The following is a description of a gene set: from publication Yevshin I, Sharipov R, Kolmykov S, Kondrakhin Y, Kolpakov F (PMID 30445619) Genes containing one or more binding sites for (ZNF274) in their promoter regions (TSS -1000,+100 bp) as identified by GTRD version 20.06 ChIP-seq harmonization. species: Homo sapiens Human Gene Set: ZNF274_TARGET_GENES, and this is the list of marker genes: ANGEL1, IMMP2L, WSB1, RASAL2, EIF2D, EFHB, AOX3P, YWHABP2, NAMPT, RPL31P63, HTATIP2, MIPOL1, ATRAID, CAPS2, TRAF3IP3, HEXA-AS1, ZCCHC2, NCOA4 (nuclear receptor coactivator 4), RPL22, UBTFL9, TP63, DPM1, SLC38A4, SRSF5, BDH1, SIDT2, TTLL5, IQCG, RPL21P7, LRRC8C, AGBL5-AS1, LINC01983, SNRPCP3, C14orf28, MT-TP, ENSG00000201701, RDH14, SNORD116-9, ACTBP12, AKAP7, SIGLECL1 (NCBI Gene Id 284369, SIGLEC family like 1), CD1E, COL4A1 (NCBI Gene Id 1282), LRRC27, PI4KA, ENSG00000234464, CLRN1, LMO7 (LIM domain 7), TPD52, LTV1, ASB13, PSMC6, IWS1, SRP54, ZNF182, PACS1, SAA2-SAA4, NAPSB, RRAGC, PSMA3, BIVM, EPB41, NXN, GTF3C2-AS2, MAPK1, HMGXB3, GCSHP2, BZW2, LINC02218, E2F3, IL17A, VPS41, MIR4273, TMEM167B, ENSG00000251922, TAT, FAM76B (family with sequence similarity 76 member B), PDE4B, BBS4, PHIP, LINC02890, TMEM19, LINC00317, LINC02278, GPR139, PHYKPL, ANXA2R, ZSCAN2, ZNF704, UTS2B, RTF1, MT-ND4, SLC39A13, POLR1HASP, ZNF791, WASH3P, ENPP5, CAPN2, AARD (alanine and arginine rich domain containing protein), SUMF1, SLC44A2, RTN1 (NCBI Gene Id 8108), RGS17P1, PSMD13, RNU6-369P, RAB3GAP2, GRWD1, ZNF324, GLI1 (NCBI Gene Id 2735), H1-4, CHTF8, PCDHA14, DST, MRM2 (NCBI Gene Id 29960), LY96, MIGA1, DBNL, RN7SL728P, ABHD12B (abhydrolase domain containing 12B), SPACA5, PSMB5, STK3, ZFHX3-AS1 (NCBI Gene Id 107984814), MEFV, PECAM1, ZFP69, HVCN1, RPS12P7 (NCBI Gene Id 100271055), ZC3H7A, MALT1, PRPS2, SRSF10, TCF7L2, STIM1, BBOX1, LCN2, PIGBOS1, FER1L6-AS2, LINC03000, SIRT1, NEIL1, MFAP3, GCNT1P3, MLIP, ATF7IP, SLC4A1APP2 (NCBI Gene Id 100422527), KIF2A, LCNL1, SNRPG, WDR53P1, EPB41L4A, INO80B, FPGS (folylpolyglutamate synthase), EFL1, MIR4473, DPH5, NAIF1, SLC1A3, UBE2D3P2, LNCRNA-IUR, CCDC71L, RNU7-110P, KRT4, HNF1A, IGLV3-29, SMPD4P1, NDUFAF4, DNM2, LINC01719, MYO1C, FIBCD1, CCDC18, GPNMB, ZNF397, NAMPT-AS1, CDC26, CROCCP2, FRMD5, MT-TS2, LIPC, IL24, HECTD1, IRAK4, FANCG, NFKBIZ, RNU6-1084P, ATXN2, IGLV1-36, RGL3, RPL17, IQGAP3 (IQ motif containing GTPase activating protein 3), RNU6-1261P, KCTD3, TYW3, SIRT3, MRPL17, GNA13, SAA2, TERB2, OSMR-DT, SIPA1L1, GGNBP1, KDM4C, TAF11L14, LUZP1, DDB2, ENTPD2, NDUFA12, DSG2, DAPK1, VENTXP4, SLC7A6, NDUFS3, ZFAND6, SPANXB1, LYSETP1, RNA5SP333, OR7A5 (olfactory receptor family 7 subfamily A member 5), LAMC3, SYNM-AS2, ERCC4, INTU, RTEL1-TNFRSF6B, EFCAB6, MITD1, YAP1, PTGER4, ITM2B, TESMIN, ENSG00000267079 (NCBI Gene Id 101927511), MTMR2, MUC6, LINC02631, UIMC1, AFDN, GFPT1, ART4, H2BC4 (H2B clustered histone 4), TRIO, LRRC36, MEIS3, DTNA, MAN1B1, TMTC1, MTND5P11, LRRC8C-DT, SKIL, ANKRD54, ZFX, ACBD6, MICU1, ZNF461, GEMIN8, CYP4A22-AS1, NOS2P1, H2AC6, DIAPH3-AS1, ANKRD22, MDM2, PANK1, ANKRD11, TANC2, ADAM10 (ADAM metallopeptidase domain 10), GCM1, ANLN, UBLCP1, PTGES2, MTND6P4, BMERB1, ENSG00000251574, ENSG00000254237, ENSG00000207751, PRC1, SREK1IP1, ATPAF2, SNORD116-7, PIWIL1, MEX3C, IFT80, RNU6-374P, FBXO34, APAF1, LIFR-AS1, RRM1, EPS8, RABGAP1L, RN7SL612P, AOAH, LINC01633, NASP, CASP7, TNS2-AS1, TPR, BRD9, LINC03126 (long intergenic non-protein coding RNA 3126), MYO15B, ASIC1, DDX11, RNF10, HSPA5-DT (NCBI Gene Id 107987127), GNA12, RPL34P17 (NCBI Gene Id 100271001), PFDN1P2, TRBV16, TBC1D2, STIL, UFL1-AS1, MARCHF6, PPP1R9A-AS1, SERINC4, RPS20P15, CCNE1, SCFD1, TMEM69, ZNF490, RN7SL812P, JPT1, ATP6V1G3, BLM, STAMBP, MTCO3P23, C2CD3, LINC00513, CSRP3-AS1, RN7SKP46, RN7SL26P, RPS13P4, CD99P1, MOGAT3, LINC02345, ARID2, DKK3, LDHD (NCBI Gene Id 197257), ENAH, RLF, ATPSCKMT, VPS13C-DT, DUX4L17, RN7SKP92, SERGEF, DNAJC17, SMIM35, CFAP57, PHLDB1 (NCBI Gene Id 23187), PCSK1, VPS26B, STRBP, IL20, TTC7B (tetratricopeptide repeat domain 7B), SNORD15B, MED26, GOT2P3, DDX11-AS1, AARSD1, TMEM216, GPR161, KIAA0319, EIF3H, TMEM9B, UBN2, TRIP10, LINC00536, VPS18, HBD, ZFYVE19, ADGRB2, PAN2, SLC35D2, UGDH, LMNA, AP3S1P1, PDZPH1P, ANAPC15, ADAM28, UBAP2, TARID, SPTLC2, IDUA, STIM1-AS1, RN7SL370P, KCNT2, YLPM1, DNAJC5B, CDH9, CCDC144NL-AS1, ENSG00000253363, MYO10, DLG1, RN7SL209P (NCBI Gene Id 106480494), FGD4, EHHADH, SNORA72, TRIM37, C8orf88, SEC63, DIAPH1, SPRR1B, SEC23A, ENSG00000254775, NRG1-IT3, CD44, ZNF101, METTL25, CMAHP, PPP2R5D, SPRY4, SYF2P2, ING3, ZNF529, SRSF3, SPAG17, CCT7P2, RNU7-47P, ARHGEF12 (Rho guanine nucleotide exchange factor 12), SHOC1, RALGAPA1, ZNF286A, NUP205, RPL7L1, GSTM3, DCAF5, TBX19, PPIAP87, RNU6-90P, MT-TR, CCL18 (NCBI Gene Id 6362), ARHGEF2, SPATA1, UACA, HMGCS2, CRLF1, MMP26, ANK3, ZNF875, ZNF621, KRT20, TMEM62, SH3YL1, PGBD2, ZNF432, TPM1, TALDO1, SRP14-DT, HECW1, QSOX2, RHOBTB3, UBE2QL1, RABEP2, RNF224, SCG3, ZNF430, PUM1, POLD2P1, CACFD1 (calcium channel flower domain containing 1), TRPC6, RN7SL615P, MRPL48, SNORD116-8, CERCAM, SETD5, MT-RNR1, GCSIR, MYCBP2-AS1, MED15, STXBP5L, VSTM5, CPAMD8, POLE2, HSPD1P15, LONRF3, LARP7P3, IDE, SLC4A8, CYCSP38, OR7A19P, SMAD3-DT (NCBI Gene Id 102723493), RNA5SP194, NCAPD3, MIR6089, INO80B-WBP1, RPL31P22, SPAG9, MIR181B2, AGBL5, RPS29P10, FAM174A-DT, LINC00881, RNA5SP368, C17orf99, ELK4, SPSB1, STK31, MT-TF, ILF3, PPP3CC, SERPIND1, RBBP7, IQCH-AS1, RSPH14, PIGB, TRBV6-2, NCOA6, SCUBE2 (NCBI Gene Id 57758), DCAF6, MUC15, MT-TH, GPC6-AS1, COX5BP4, TULP2, DLGAP2, EEF1A1P39, PTGS2, LIFR, ZNF274, SMG5, RNA5SP110, LINC01596, GLMP, TMEM183A, IL6ST-DT, ZNF692 (zinc finger protein 692), HIPK1, SNORA63, LSM11, RNU6-1209P, RPL18A, PKM, MYOT, SNORD116-10, CFAP69, KCNQ2 (potassium voltage-gated channel subfamily Q member 2), RPS27P30, POLR2K, FHL2, LRRC40, CCT7, RN7SKP25, NT5C3A, ST13P21, LMAN1, ACRBP, NOL4, GXYLT1, MATCAP2, LYPD3, DEPDC4, SSBP2, DAP-DT, SELENOS, RERE (arginine-glutamic acid dipeptide repeats), OR13Z2P, PRDX1, SEH1L, ARPC3P1, AHCYL2, PLSCR4, ZPLD1, ANKRD29, SUCO, RNF145, YWHAQP6, CCDC69, FAM114A2, GLI2, C22orf39, NAT10, NCKAP1L, SLC38A4-AS1, ASPM (NCBI Gene Id 93990), MIR107, RAB13, MED6P1, LINC02058, NUF2, FZR1, TCTN1, LZTR1, IGLC7, GLS2, H3C12, LRRC19, BDNF-AS, MAGEB6B, LINC01497, AFG1L, LINC02687, WDR11, ARFGAP2, ZNF473CR, XXYLT1, SEMA4B, AGR3, TP53, ACCSLP1, PSMB7, SUMO2P13, STXBP2, DTWD1P2, MST1P2, PDE4D, EIF1AX-AS1, JPH3, LINC00963, HNRNPC (NCBI Gene Id 3183), PHF14, RN7SL420P, MT-TG, MRPL15P1, LBR, NCKAP5L, BORCS7, SET, MTCO3P12, PSIP1, LINC02143, OR2R1P, LINC00635, ZNF491, PRKAA1 (protein kinase AMP-activated catalytic subunit alpha 1), MT-TT, MTND1P15, SERPINC1, PODNL1, NAXE, BRD3OS, LRRC7-AS1, PPIEL, PCNX1, CYP1B1, PCLO, MINDY4B, COX5BP8, RN7SKP104, CEPT1, SGMS1, CWC27, MAP2K6, UTP14A, AIF1L, ZNF354B, CCDC190, SNHG17, MT-TL1, RNA5SP286, MRPL45, ALG3, WNK1, PPP2R5C, TFAP2A, GPBP1L1, ADAMTS13, MIR4502 (NCBI Gene Id 100616227), LINC01503, RNU7-93P, CYCSP19, YES1, PFKL, PYM1, ZNF737, ENSG00000278464, CRYZ, PLPP2, RPL11, HMCN1, RO60, GANAB, MRPS5, IL2RA, OFD1P17, RHOH, ZNF706, MT-CYB, PARP10, UCK2, GCSHP1, PHC3 (NCBI Gene Id 80012), SLC45A2, ENSG00000231964, GHR, RNU6-8, ABCC1, PEX14, PLCE1P1, RPS26P28, NEK8, LETMD1, MRPL57P3, NARS2, KIAA0753, GYS1 (NCBI Gene Id 2997), EMC4, ZNF574, CHASERR, G2E3-AS1, ZNF382, SPPL3, TNKS, ERMAP (erythroblast membrane associated protein (Scianna blood group)), HACD2, LINC02989, PAGE4P1, ARPP21, PDGFB, AOX2P, ZNF420, AKAP8P1 (NCBI Gene Id 646114), FOSL1, TMEM248, RN7SL577P, ARHGAP5, MSS51, ZMYM4 (NCBI Gene Id 9202), ABCB9, PARAIL (palmitic acid regulated anti-inflammatory lncRNA), SLC37A1, GPR108, DIAPH1-AS1, SLK, PDCD4, INO80, DPH5-DT, TMEM212, ZNF836, DDX39BP2, MID1, CHST11, ACAP2, KRIT1, NOCT, MORF4L1P1, CRLF3P3, THUMPD3, NCOA3, NTHL1, RRAGA, EIF3FP1, DTNB, RNF144B, LINC02908, MPPE1, PTPRQ, FBXO22 (F-box protein 22), ALDH7A1P4, TWF1P1, MT-ND4L, ST6GAL1, PLD1, FYB1, FNBP4, GON4L, RPL36AP40, IFT25, C1orf167, DIAPH3, ZNF613, RAD51B, PHF20, FBN2, RPL35AP32, SRSF1, HAGH, LINC01960, SLC22A2, G2E3, CPXM1, CELA3A, DUX4L18, DROSHA, FANCA (FA complementation group A), RNU1-39P, RN7SL334P, NT5DC3, PPM1B, ANKRD13D, MIP, CSF2RA, UBA5, ACER3, VTRNA1-2, BPTF, HRH4, ATP2A2, COX7CP3, CNTF, LRCH3, RNU7-87P (NCBI Gene Id 100873842), GPI, ATP6V1B2, GTF2B, FAM220A, SVOP, ZBED3-AS1, PTPN11P4, HNRNPH3, DAPK2, ERCC8, SEPTIN2, MAT2B, ZNF43, RSRC2, DENND1B (NCBI Gene Id 54530), RSPH3, SF3A3, TTC9C (tetratricopeptide repeat domain 9C), RPS29P14, SLC38A9, MAN1B1-DT, AP3M2, SNX29, ADNP, ANKRD55, SLC22A15, CPLANE1, CNIH3, MIR4740, RIPK2, BBC3, RC3H1, RN7SL76P, PIK3IP1-DT, OSBPL3, NBPF1, BASP1, MR1, RPLP1 (ribosomal protein lateral stalk subunit P1), RDH5, GARS1-DT (NCBI Gene Id 402475), ZSCAN10, FBXO34-AS1, GARNL3, PPARGC1A, OAZ2, RAF1 (NCBI Gene Id 5894), HMGB1P35, MIR4437, CENPK, MIR3651, GDF15, COQ10B, PCED1B, PMFBP1 (polyamine modulated factor 1 binding protein 1), CLDN10, RNA5SP460, CHRNA5, VPS33B-DT, PAK2, MTAPP1, ZNF410, MLF2, ZBTB18, GLUD1P3, MT-ND6, C1QTNF3, MT-TE, PPM1F, CARS2, NET1, ZFAND4, GIPR, NUP188, ZNF566, LINC01828, CHI3L2, CYP11A1, ENSG00000261838, CHD2, FAAP100, SNORD116-3, CALD1, SRR, COMMD1, RDH13, ZNF525, DDX23, HM13, ZNF354A, FAM174A, ZNF263, BRMS1L, BRME1, XYLT2, RNF111, FABP4, SNORD116-5, CROCC, BTBD9, PPDPFP1, SV2B, RN7SL693P, RGMB, FAM177A1, NCLN, CCT5, FMO5 (NCBI Gene Id 2330), SESN3, CNTRL, LRPAP1 (NCBI Gene Id 4043), YAF2, GPRC5A, SQLE, RHOT1 (NCBI Gene Id 55288), RAI14-DT, MADD, MTMR12, SPTAN1, KCTD19, FADS2B, BRIP1, NTN4, NEUROD4, DAOA, CABLES1, DUX4L52, ARRDC1 (arrestin domain containing 1), RNA5SP21, GNB5, POLR1B, FARP1, MIR3650, MTFR2P1, HCG14, TCF12, GATB, CISTR, DUSP11, PTEN, SNORA84 (small nucleolar RNA, H/ACA box 84), LGR4-AS1, CDH6, PLAC8, GAPDHP33 (NCBI Gene Id 650440), CHL1-AS1 (CHL1 antisense RNA 1), TMCO1, MESP1, RPL13AP9, FBH1 (F-box DNA helicase 1), COPZ2, VASP, WDR73, RAD50, LINC02736, GSDME, MIR3150A, ST8SIA1, LCDR, TMEM9B-AS1, SNORD116-1, RACK1P1, CCDC73, GNLY, SLBP, SSBP3 (NCBI Gene Id 55126), ITGA6, AK9, UBE3A, GBA1LP, PTTG1IP2, NUP214, AHRR, TRAPPC6B, DLGAP5, UBIAD1, SMAD6, RORA, GPR21, TTLL3, VENTXP5, RPL36AP2, NRSN1, FAM177B, CCDC183-AS1, IKZF4, ENSG00000258657, RN7SKP153, PRMT9, C15orf61, MCCC1, LRRC37B, GFM1, PHACTR4, TRNT1P1, MTND3P12, DGKA, ANKRD24, EML2, NUDT1, CDYL2, IGLV8-61, DCP2, RPL7AP40, PTCSC2, CDK16, DYNLT4, ADCY2, TNS2, M6PR, RNA5SP435, GNA14, MT-ND3, RN7SL280P, PI16, USP49, LARP4, IGLC5, TMBIM6, PTK2, BBS9 (NCBI Gene Id 27241), HSPE1P27, FHL1, TCF21, MMUT, ESPL1, MYG1-AS1, NFIB, RPS26P40, PRDM9, WDR33, CFDP1, SMASR, ENSG00000229664, RNU6ATAC11P, RN7SL354P, ARMC2, HYPK, ZNF701, POLL, ELMO2, MTMR1, WDCP (WD repeat and coiled coil containing), ABCF1, IQCB2P, ZNF484, PABPC4, OR51Q1, ANAPC7, RAB40B, FARSA, RUBCN, ZNF48, STPG4, RPL17-C18orf32, PEX5L, RNA5SP444, LINC01322, MTERF1, RNY4, CREBBP, HNRNPA1P16, ATOSA, PRKAR2B, C9orf57, H3P21, AXDND1, FJX1, MINDY2-DT, ZNF607 (NCBI Gene Id 84927), OR4C3, NR4A2, ZRSR2P1, C4BPAP1, CPVL-AS1, LINC00665, RNF19A, TRAPPC12, TBC1D28, MT-ND1, ZNF10, BICRAL, CLMP, ZIC1, SBF2, GRHL1, BST2, SENP5, MED13L, RNF130, NID2, ARPC1AP1, FUT8-AS1, SOX6, ZNF879, VRK2, MT-TL2, FAHD1, DRAM2, NFAT5, ACSM3, LDHB, RAPGEFL1, ENSG00000247131, ZFHX3, EXOC3-AS1, PTRHD1, RTTN, SCG5, RIMKLBP2, ZNF350, ZNF808, DAB2, HDAC11, TMEM219, KHDRBS3, AFG3L1P, GGNBP2, HRG-AS1, DDX5, CCDC77, GTF3C2, ZNF598, RN7SL782P, LINC00652, EEF1G, C2orf92, ABI3BP, RN7SL444P, RALGAPB, KMT2D, HDAC11-AS1, RNU6ATAC24P, EGR2, RNU6-1248P, IGLV3-6, BTAF1, RPS15AP29, SV2A, TPP2, RPS6KC1, RPL35AP6, CCDC146, CENPQ, PRH2, RAB27A, NUBPL